Given this list of marker genes Ddx28, Fastkd2, Dhx30, Mrm2, Rcc1l, here is a description of the gene set: The aggregation, arrangement and bonding together of a set of components to form a mitochondrial large ribosomal subunit. studied in species Mus musculus Mouse Gene Set: GOBP_MITOCHONDRIAL_LARGE_RIBOSOMAL_SUBUNIT_ASSEMBLY